Given this list of marker genes AQP1, SLC4A1, CA4, CA2, CA1, CYB5R2, CYB5R4, CYB5R1, RHAG, CYB5RL, HBB, HBA1 (hemoglobin subunit alpha 1), here is a description of the gene set: Carbon dioxide (CO2) in plasma is hydrated to yield protons (H+) and bicarbonate (HCO3-) by carbonic anhydrase IV (CA4) located on the apical plasma membranes of endothelial cells. Plasma CO2 is also taken up by erythrocytes via AQP1 and RhAG. Within erythrocytes CA1 and, predominantly, CA2 hydrate CO2 to HCO3- and protons. The HCO3- is transferred out of the erythrocyte by the band 3 anion exchange protein (AE1, SLC4A1) which cotransports a chloride ion (Cl-) into the erythrocyte.<br>Also within the erythrocyte, CO2 combines with the N-terminal alpha amino groups of HbA to form carbamates while protons bind histidine residues in HbA. The net result is the Bohr effect, a conformational change in HbA that reduces its affinity for O2 and hence assists the delivery of O2 to tissues. studied in species Homo sapiens part of: O2/CO2 exchange in erythrocytes Reactome Pathway: Erythrocytes take up carbon dioxide and release oxygen